Given this list of marker genes Nsun5, Mecp2, Smo, Cep120, Pax6, Bhlhe22, Wdr62, Phactr1, Atic, Ascl1, Lamb1, Akirin2, Kcna2, Dmd, Fbxo45, Fktn, Mdga1, H2ax, Tacc1, Lhx6, Ccdc39, Fos, Rhoa, Fgf13, Ccdc85c, Pafah1b1 (NCBI Gene Id 94322), Nefl, Zmiz1, Dab1, Dab2ip, Mcph1 (NCBI Gene Id 71346), Aspm, Tacc2 (NCBI Gene Id 57752), Rac1, Gart, Lhx2, Celf1, Bbs2, Tbr1, Tubb2a, Rtn4, Tfap2c, Robo1, Grin1, Syne2, Fat4, Gria1, Gsk3b, Nfix, Col3a1, Foxg1, Emx1, Filip1, Bbs4 (Bardet-Biedl syndrome 4), Socs7, Cul5, Cdk5, Bmerb1 (bMERB domain containing 1), Nf1, Mkks, Eomes, Kif26a, Afdn, Trappc9, Gli3, Pex5, Nr2f1, Psen1, Nars1 (NCBI Gene Id 98111), Pou3f2, Ptprs, Efhc1, Pals1, Nkx2-1, Arx, Ndel1, Adgrg1, Sox2, Wdr47, Cdh2, Lrp6, Egfr, Rnf7, Tacc3, Slc38a2, Nr2e1, Fut10, Mdk, Atoh1, Sun1, Kcna1, Hnrnpk (NCBI Gene Id 15387), Nde1 (NCBI Gene Id 67203), Dicer1, Ntrk2, Emx2, Cdk5r1, Sun2, Atg7, Bnip3, Hif1a (NCBI Gene Id 15251), H2aj, Slc2a1, Tsc1, Dixdc1 (NCBI Gene Id 75356), Htr6, Ulk4, Mgarp, Tuba1a, Lrp8, Ywhae, Atp1a3, Plcb1 (NCBI Gene Id 98861), Disc1, Pou3f3, Ppp1r9b, Flna, Crk, Cdk5r2, Ncoa1, Tra2b, Csnk2a1, Pax5, Dmrta2, Cdon, Srgap2, Tubb2b, Ctnnb1, Reln, Th, Npy, Dcx, Slit2, Mboat7, Kdm1a, P2ry12, Btbd3, Pex13, Bbs1, Bax, Ccdc141, Kif14, Crkl, Fgfr1, Zbtb18, here is a description of the gene set: Mouse Gene Set: GOBP_CEREBRAL_CORTEX_DEVELOPMENT The progression of the cerebral cortex over time from its initial formation until its mature state. The cerebral cortex is the outer layered region of the telencephalon. species: Mus musculus